The following is a description of a gene set: species: Homo sapiens Human Gene Set: GOBP_AUTOPHAGOSOME_ORGANIZATION A process that is carried out at the cellular level which results in the assembly, arrangement of constituent parts, or disassembly of an autophagosome., and this is the list of marker genes: MAP1LC3C, DNAJC16, RAB19, AP4M1, ATG5, GABARAPL1, BECN1, SNX7, PIP4K2A (NCBI Gene Id 5305), RAB1A, TOM1, SH3GLB1, UBQLN1, RAB5A, ATG3, ATM, IRGM, ATG14, TP53INP1, RAB43, ATG4B, MTOR, FEZ1, TMEM39A (NCBI Gene Id 55254), ATG9A, ATG10, TRIM32, RETREG1, IFT20, RNF5, PIK3C3, MAP1LC3B, RB1CC1, LRSAM1, ATG16L1, ATG2A, C9orf72, NUPR1, TMEM41B, IRGQ, FEZ2, RAB7A, GBA1, ATP13A2, ATP2A2, PIK3C2B, LRBA, RAB3GAP2, UBXN2B, SMURF1, MTM1, CLN3, PINK1, RAB1C, CTSD, RALB, BAG3, NSFL1C, ELAPOR1, ATG101, EPM2A, ATG9B, RETREG2, RAB3GAP1, ATG4C, EMC6, MAP1LC3B2, ZFYVE26, PIP4K2C, ULK3, SPG11, STING1, STBD1, ATG4A, RAB33A, WDR45, WIPI2, RUFY4, GABARAPL2, AP5Z1, PIKFYVE, TP53INP2, ATG7, GABARAP, GABARAPL3, MTMR3, SNX18 (sorting nexin 18), UBQLN2, TBC1D14, EPHB2, AMBRA1, TRAF6, UBXN2A, WDR45B, RNF186, VMP1, ATG13, IFT88, ATG2B, ATG4D, STX17, EHMT2 (euchromatic histone lysine methyltransferase 2), ATG12, BECN2, LRRK2, ATG16L2, MOAP1, PACS2, RAB23, SNX4, SNX30, RETREG3, ARFIP2, MAP1LC3A, PHF23, SCFD1, CHEK2, SEC22B (SEC22 homolog B, vesicle trafficking protein), MFN2, PSEN1, BNIP3, ULK1, PIP4K2B, EFNB1, TBC1D12, SMCR8, STX12, WIPI1, TCIRG1, ULK2, RAB33B, ELAVL1, RAB1B